Given this list of marker genes GLRA3, NLGN2, GLRA2, ITGB3, NPPA, GLRA1, GPHN, IQSEC3, GLRB, here is a description of the gene set: A synapse that uses glycine as a neurotransmitter. studied in species Homo sapiens Human Gene Set: GOCC_GLYCINERGIC_SYNAPSE